Given this list of marker genes C1orf35, NCSTN, C6, FBLN1, TRPS1 (transcriptional repressor GATA binding 1), GPC3 (NCBI Gene Id 6394), SULT1E1, EXOG, GRIK2, ZNF74, ZNF212, MACF1, PTGER4, MANSC1, NACA4P, GOLGA3, DENND1C, RRBP1, SPHK2, HMCES, TAF15, MYBL2, OTUD3, ECE1, NDOR1, NPFF, FOSB, SLC25A37, AVPR1B, FBXW12, EPHB4, MRTFB, MCM9, MRPL24, AP1G2, LRP1, KLHDC4, PLA2G4C, TCN2, LMNB1, TULP4, KAT2A, TMEM53, EZH2, CHD4, ASB13, SAC3D1, CLEC4E, GINS3, DDX51, NBEAL2, SHMT1, CDK5RAP3, FLNA, MAPK8IP3, TGFB2 (NCBI Gene Id 7042), ARRB1 (arrestin beta 1), MN1, CLBA1, ADGRF5, RBM4B, PPP1CB, YTHDC2, APOM, KIF26B, TCF21 (NCBI Gene Id 6943), GOLGA8A, ZFHX3, EBLN2, PTBP2, INSR, HTR2A, CDH22, ARHGEF11, SLC22A11, ZNF219, RASSF2, POLD3, MYDGF, PRKD1, MECP2 (NCBI Gene Id 8274), SCD5, KLHL25, SMC2, FXYD6, RCBTB1, CLOCK, PRPF39, SMPD2 (NCBI Gene Id 6610), SORBS2 (NCBI Gene Id 8470), PRPH, MTARC1, GSDMB, SAP30L-AS1, IMPACT, CLN8, ACVR2B, OLR1, PRUNE1, ZNF428, PLD3 (NCBI Gene Id 23646), ZBTB48, MCAM, B3GNTL1, INAVA, SIRT5, CYP1A2, TOMM40, ZZEF1, PIK3CB, NUDT6, CTSH, SLC4A7, ZNF318, SFRP1, TMEM106C, EXOSC5, HSD17B14, TRIM24, KIF14, METRN, BORA, PPP1R14D, CEP72, UBB, LIAS, SORBS1, MRPL17, CSTPP1, BAHCC1, SLC16A5, CSPG4, EFNA4, SLC7A11, INTS14, MAGOHB, CKB, DOP1A (DOP1 leucine zipper like protein A), LRIG2, MT1F, ACAN, NMB (NCBI Gene Id 4828), NTF3 (neurotrophin 3), NEK2, ATF7IP, LHPP, FGF9, FXYD1, ASCL1, PITPNM3, DOCK9, ZNF215, PBX2, NRGN, MRPL34, DOCK4, CLCC1, ATP9B, RNF128, TRPM4, SPACA9, HSD17B6, CNTN1, SLC11A1, ZNF324, PROZ, ST3GAL6, SYNE2, MS4A6A, S1PR1, HPN, SREBF1, NAA16, ZKSCAN4, SLC12A9, VGLL3, FRMD4A, PRDM11, KIAA1549L, CLCNKB, ARNT2, TGFBR3, NIPSNAP3B, IRGQ, RDH5, BAZ2B, FXN, KNTC1, AFP, KRIT1, KIFC1, ZNF500, VPS13A, NPTXR, ZFHX4, OR3A1, here is a description of the gene set: studied in species Homo sapiens Human Gene Set: GSE37534_UNTREATED_VS_ROSIGLITAZONE_TREATED_CD4_TCELL_PPARG1_AND_FOXP3_TRASDUCED_UP Genes up-regulated in CD4 T ceels over-expressing FOXP3 and PPARg1 isoform of PPARG: untreated versus rosiglitazone. from publication Cipolletta D, Feuerer M, Li A, Kamei N, Lee J, Shoelson SE, Benoist C, Mathis D (PMID 22722857) Pioglitazone treatment of CD4+FoxP3- T cells transduced with Pparg and Foxp3 up-regulated a set of genes whose products have been implicated in lipid metabolism pathways. To verify the specificity of this treatment, we performed microarray analysis on Foxp3+Pparg1-transduced CD4+FoxP3- T cells after treatment with other PPARg agonists such as Rosiglitazone (TZD) and GW1929 (non-TZD).